The following is a description of a gene set: Human Gene Set: HP_AORTIC_TORTUOSITY species: Homo sapiens Abnormal tortuous (i.e., twisted) form of the aorta. Aortic tortuosity, and this is the list of marker genes: SMAD6, SMAD3, ATP6V1A, TGFB2, IPO8, MFAP5, SLC2A10, SMAD2